The following is a description of a gene set: from publication Chen Y, Wang X (PMID 31504780) Mouse Gene Set: MIR_6516_5P Genes predicted to be targets of miRBase v22 microRNA mmu_miR_6516_5p in miRDB v6.0 with MirTarget v4 prediction scores > 80 (high confidence targets). species: Mus musculus, and this is the list of marker genes: Uspl1, Gm6710, Lefty1, Rab10, Atp2b4, Ets2, Sema4b, Arpp21, Adam22, Mbd1, Hesx1 (homeobox gene expressed in ES cells), Hhip, Ptprt, Gm2026, Fign, Snx5, Cx3cr1, Sgip1, Dop1a, Zfp36l1, Ntng1, Pcdh11x, Ror1, Cabp5, Nup160, Gpr149, Qki, Gm14325, Abl2, Irf2bpl, Dffb, Prnd, 4933402D24Rik, Zfand6, Kctd4, Gbp2b, Hdac9, Abi3bp, Paip1, Traf3, Lgals8, Gdi2, Ccn1, Slamf7, Zfp735, Tmem47, Mospd1, Myh10, Rsrc1, Ifih1, Larp4b, Ski, Camk1d, Fbxl2, Igsf1, Gm14308, Gm20939, Jagn1, Piezo2, Flrt3, St3gal6, Fam170b, Pgam5, Rev3l, Brca1, Lrp8, Adnp, AW554918 (expressed sequence AW554918), Ephb1, Rassf9, Mdc1, Actb, Dmbt1, Gnai2, Atp8a1, Gnal, Tnfaip8l3, Acbd6, Gm14434, Slc30a1, Csnk1g3, Ccdc96, Hipk3, Tmem220, Epb41l1, Cggbp1, Slc12a6, Gpr17, Coil, Sh3yl1, Nptx1, Nwd1, Plagl1, Pabpc4l, Dip2a, Gspt1, Itga6, Sec31a (SEC31 homolog A, COPII coat complex component), Flvcr2, Aak1, Man1a, Rhov, Zfp235, Ptpmt1, Usp25, Eif4g3, Slc17a6, Cntn3, Abhd5, Chek1, G3bp2, Gm13275, Dtx4, Gm4724, Csmd3, Shank2, Rtn1, Depdc1b, Rab3c, Rtn3, Ssh2, Cebpd (NCBI Gene Id 12609)